Given this list of marker genes Prox1, Pou2f1, Six4, Ctnnb1, Frs2, Eda, Lrp6, Tbx2, Hdac2, Hdac1, Tbx3, Foxi3, Gnas, Nrg3, Nrp1, Six1, Sox2, Dkk4, here is a description of the gene set: The progression of an ectodermal placode over time from its initial formation until its mature state. An ectodermal placode is a thickening of the ectoderm that is the primordium of many structures derived from the ectoderm. species: Mus musculus Mouse Gene Set: GOBP_ECTODERMAL_PLACODE_DEVELOPMENT